Given this list of marker genes DPY30, KDM6A, NCOA6, KMT2D (NCBI Gene Id 8085), WDR5, RBBP5, KDM6B, UTY, KMT2C, PAGR1, ASH2L, PAXIP1, here is a description of the gene set: A protein complex that can methylate lysine-4 of histone H3, and which contains either of the protein subunits MLL3 or MLL4 in mammals, or equivalent in other species. studied in species Homo sapiens Human Gene Set: GOCC_MLL3_4_COMPLEX